The following is a description of a gene set: Mouse Gene Set: GOBP_INTRACELLULAR_STEROL_TRANSPORT studied in species Mus musculus The directed movement of sterols within cells., and this is the list of marker genes: Pcsk9 (NCBI Gene Id 230573), Vps53, Arv1, Vps4a, Serac1 (serine active site containing 1), Abcg1 (ATP binding cassette subfamily G member 1), Nus1, Vps52, Scp2, Relch, Abca1, Tspo2, Npc2, Osbpl2, Vps51, Abca2, Osbp, Vps54, Ldlr, Star, Syt7, Anxa2, Gramd1a, Ldlrap1, Gramd1b, Tpcn2, Pip4k2a, Stard4, Arl8b, Snord60, Lrp6, Tmem97, Gramd1c, Npc1